The following is a description of a gene set: Mouse Gene Set: GOBP_INTERLEUKIN_17A_MEDIATED_SIGNALING_PATHWAY species: Mus musculus The series of molecular signals initiated by interleukin-17A binding to its receptor on the surface of a target cell, and ending with the regulation of a downstream cellular process, e.g. transcription., and this is the list of marker genes: Map3k7, Il17rc, Traf3ip2, Il17a, Traf6, Il17ra (NCBI Gene Id 16172)